The following is a description of a gene set: Any process that activates or increases the frequency, rate or extent of MAP kinase activity. Mouse Gene Set: GOBP_POSITIVE_REGULATION_OF_MAP_KINASE_ACTIVITY species: Mus musculus, and this is the list of marker genes: Tnfrsf11a, Ntrk3, Axin1, Kitl, Tirap, Ptprc, Fgd2, Nek10, Tpd52l1, Pdgfb, Hras, Thbs1, Zeb2, Map2k6, Flt1, Ccl19, Robo1 (NCBI Gene Id 436378), Tenm1, Traf2, Pak1, Map2k7, Ccr7, Fgf2, Edn3, Pdcd10, Arhgef5, Htr2b, Egfr, Pde5a, Erp29, Fgf18, Adam9, Ezh2 (enhancer of zeste 2 polycomb repressive complex 2 subunit), Fzd4, Fgf1, Ern2, Psen1, Mst1r, Il1b, Fcer1a, Lrrk2, Fzd8, Irak1, Maged1, Cd24a, Fgd4, Map3k5 (mitogen-activated protein kinase kinase kinase 5), Map3k13, Nox4, Syk, Dab2ip, Cripto, Sash1, Pik3r5, Edn1, Wnt5a, Taok3, Map2k4, Epha4, Rasgrp1, Gpr39, Insr, Bcl10, Pik3cg, Fgfr1, Rps3, Map3k1, Ntf3 (neurotrophin 3), Fzd5, Map3k7, Erbb2, Ptpn1, Magi3, Ceacam1, Map3k10, Il34, Map3k12, Gab1, Adra2a, Pdgfa, Pik3r6, Pdgfrb, Dusp19, Tlr6, Ager, Map4k2, Ern1, Kit, Tnfsf11, Drd4 (NCBI Gene Id 13491), Ajuba, Map3k4, Map3k11, Dvl2, P2rx7, Cd40, Vangl2, Tnf, Tlr4, Mapk8ip3, Traf6